The following is a description of a gene set: studied in species Homo sapiens Interleukin 12 (IL-12) is heterodimeric cytokine produced by dendritic cells, macrophages and neutrophils. It is encoded by the genes Interleukin-12 subunit alpha (IL12A) and Interleukin-12 subunit beta (IL12B), which encode a 35-kDa light chain (p35) and a 40-kDa heavy chain (p40), respectively. The active IL12 heterodimer is sometimes referred to as p70. The p35 component has homology to single-chain cytokines, while p40 is homologous to the extracellular domains of members of the haematopoietic cytokine-receptor family. The IL12 heterodimer therefore resembles a cytokine linked to a soluble receptor. IL12 is involved in the differentiation of naive T cells into Th1 cells and sometimes known as T cell-stimulating factor. IL12 enhances the cytotoxic activity of Natural Killer cells and CD8+ cytotoxic T lymphocytes. IL12 also has anti-angiogenic activity, mediated by increased production of CXCL10 via interferon gamma. The IL12 receptor is a heterodimer formed by Interleukin-12 receptor subunit beta-1 (IL12RB1) and Interleukin-12 receptor subunit beta-2 (IL12RB2), both of which have extensive homology to IL6ST (gp130), the signal transducing receptor subunit of the IL6-like cytokine superfamily. IL-12RB2 is considered to play the key role in IL12 function, in part because its expression on activated T cells is stimulated by cytokines that promote Th1 cell development and inhibited by those that promote Th2 cells development. In addition, IL12 binding leads to IL12RB2 tyrosine phosphorylation, which provides binding sites for the kinases Non-receptor tyrosine-protein kinase TYK2 and Tyrosine-protein kinase JAK2. These activate transcription factor proteins in the Signal transducer and activator of transcription (STAT) family, particularly STAT4. part of: Interleukin-12 family signaling Reactome Pathway: Interleukin-12 signaling, and this is the list of marker genes: CNN2, MTAP, IL12RB2, SOD1, IL12RB1, PITPNA, HNRNPA2B1, TALDO1, PSME2, PPIA, IL12A, P4HB, STAT4, CA1, SNRPA1, PAK2, ARF1, AIP, LCP1, PDCD4, RPLP0, IL10, IFNG, SOD2, GSTO1, CDC42, RALA, JAK2, IL12B, HNRNPF, SERPINB2, RAP1B, GSTA2, MIF, CAPZA1 (capping actin protein of muscle Z-line subunit alpha 1), LMNB1, ANXA2, MSN, VAMP7, HNRNPDL, TCP1, BOLA2, HSPA9, TYK2, JAK1, CFL1